The following is a description of a gene set: Human Gene Set: REACTOME_NON_INTEGRIN_MEMBRANE_ECM_INTERACTIONS species: Homo sapiens Non-integrin membrane-ECM interactions, and this is the list of marker genes: THBS1, COL4A6, NTN4, ITGA6, TTR, COL1A2, PRKCA, VTN, SNTB1, ACTA1, ACTG2, LAMA3, SNTB2, SDC4, LAMA4, COL11A1, SDC2, DAG1, LAMA2, LAMB2, DTNA, ITGB1, TNC, PDGFA, COL10A1, COL4A5 (collagen type IV alpha 5 chain), COL4A1, ACTA2, SNTG2, SGCD, SGCA, DRP2, COL5A3, SGCZ, DDR1, COL5A1, ACTG1, COL4A4, COL4A2, ITGB5, SNTA1, NRXN1, DDR2, ACTC1, SGCB, LAMB1, SGCE, LAMA5, LAMC2, COL3A1, ITGB4, SDC1, ACTB, ITGAV, HSPG2, UTRN, LAMC3 (laminin subunit gamma 3), TRAPPC4, TGFB1, ACTN1, DMD, LAMB3, DTNB, LAMC1, PDGFB, SDC3, SGCG, LAMA1, COL11A2, CASK, ITGB3, ITGA2, FGF2, COL1A1, COL5A2, COL2A1 (collagen type II alpha 1 chain), COL4A3, FN1, SSPN, AGRN